Given this list of marker genes MAP2K2, TNNI3K, PIKFYVE, ERN1, ATM, RIPK1, here is a description of the gene set: Human Gene Set: GOBP_PEPTIDYL_SERINE_AUTOPHOSPHORYLATION The phosphorylation by a protein of one or more of its own serine amino acid residues, or a serine residue on an identical protein. species: Homo sapiens